Given this list of marker genes LIPE, GK, DGAT1 (diacylglycerol O-acyltransferase 1), MOGAT3, GNPAT, AGPAT2, LIPF, LPL (lipoprotein lipase), AGPAT4, AGPS, PLPP2, DGAT2, MOGAT1, GK2, PLPP3, GPD1, AGPAT1, LIPC, PNPLA2, PLPP1, AGPAT5, MOGAT2, GPAM, AGPAT3, here is a description of the gene set: Human Gene Set: WP_TRIACYLGLYCERIDE_SYNTHESIS studied in species Homo sapiens Triacylglyceride synthesis